Given this list of marker genes Gm11533, Eif5 (NCBI Gene Id 72643), Ubald1, Sf3b4, Il12a, Utp3, 1110002O04Rik, Asap1, H2ac8 (H2A clustered histone 8), Pip5k1a, Cd38, Wdr5b, Esyt2, Neurl1a, Ilvbl, Slc35b4, 1110002E22Rik, Mplkip, Erlec1, Mir8101, Trib2, Entpd6, 4933407L21Rik, Rps15a, Tmem186, Tmem11, Gm6822, Dcaf1, Ndrg4, Sra1, Zbtb18 (NCBI Gene Id 30928), Zfp652, Grk4, Ptprt, Prdm10, Spty2d1, Negr1, Mir7010, Dlgap2, Neurl4, Ccdc163, 1600029O15Rik, Eif2b4, Sumo3, Rasgrp3, Caly, Mrpl30, Kcnj3, Rab15, Nbea, Ndel1, Gas7, Gm15423 (NCBI Gene Id 102640747), Zfp933, Cdca3, Dusp14 (dual specificity phosphatase 14), Ppa2, Rpgrip1l, Lysmd1, Rab40b, Virma, Ccdc61, Nepro, Rufy2, Dbt, Atp6v0a1, Rnu11, Fhad1os2, Rwdd4a, Cad, Cenpu, Dcps, Tars1 (threonyl-tRNA synthetase 1), Rab40c, Dcp1b, Mrpl13, Sox11, Kif1b, Wbp1, Gm25296, Ephb1, Ppp6r1, Wsb2, Usp10, Ninj2, Mindy3, Fhad1, Dbh, Ppt1, Stx1a, Prss36, Atp6v0d1, Zfp146, Ddrgk1, Rad51b, Arap2, Desi1, Kalrn, Ncam1 (NCBI Gene Id 17967), Cdk7, C1ql3, Prrc2a, Akirin2, Cdr1os, Zfp455, Poc1a, Pkd1l3, Gadd45g, Usp2, 4930579G24Rik, Zw10, Gm24552, Nr4a1, Ssc4d, B230369F24Rik, Aggf1, Plpp6, Prrg2, Polr1h, Hspa1l, Arid3a, Hsd11b1, Fer1l4, Map6, Pmm2, Cdk12, Ankrd40, Stxbp1, Ift70a1, Pnrc1, Rtl3, Nhp2, Mmachc, Snx1, Gpn3, Gm38250, Mtcl1 (microtubule crosslinking factor 1), Cbr1b, Rasa3, Ssbp2 (NCBI Gene Id 76496), Carf, Gm25151, Adgrl1, Cstf2t, Zfp524, Zfp719, Rsrc2, Lmo7 (LIM domain only 7), Stambpl1, Crebl2, Zfp260, Gm11465, Garnl3, Tbcd, Gm3764, Hsp90b1, Dip2b, Nop14, Otud6b, Tcap, R3hdm2, Mad2l1, Nolc1, Clvs1, Eif3d, Rpa2, Mir5122, Gramd1b, Yars1, Rhoa, D030040B21Rik, Ckap2l, Commd4, Ankrd28, Ddx41, Ppm1b, Maco1, Btrc, Ciart (circadian associated repressor of transcription), Atxn2l, Ssh2, Cfl1, Mttp, Gm8369, Pgap2, Gabpb2, Tgfbr1, Zfp605, Gm3332, Arhgap11a, Cbx7, Tbc1d23, Celf3, Ipo8, Cpvl, Ephx4, D330050G23Rik, Fbxo5, Fam131a, Fam216a, Tacc3, Gsk3a, Zfp335, Bcas3, Hsf2bp, Smarcb1, Psmb6 (proteasome (prosome, macropain) subunit, beta type 6), Kxd1, Cnep1r1, Gm25939, Pcca, Nuf2, A430005L14Rik, Map3k12, Ugcg (NCBI Gene Id 97164), Elmo2, Mir100hg, Apba2, Tmem184b, Atosa, Or2y1f, Zfp708, Ddx39b, Cox11, Phb2, Setd4, Sirt2, St3gal2, Pkm (pyruvate kinase, muscle), Rubcn, Eif5a, Slc9a1, Pja2, Napg, Gpbp1, Gm29346, Ces1a, Esco1, Arid3b, Mir1945, Anapc7, Gm24641, Rnf126, Rpl18, Haus6, Sugct, Thnsl1, Rab31, Astn1, Hnrnph1 (NCBI Gene Id 59013), Gm15737, Btbd10, Spred2, Kbtbd3, Sptbn2, Trim2, Egr4, Tfg, Gm28578, Arhgap10, 2810408A11Rik, Ubac1, Dhodh, Vipr1, Ppp4r1, Pfkm, Pacsin3, Hycc2, Arl16, Nfkbib, Gm19705 (predicted gene, 19705), Mtbp, Arf2, Serpini1, 9130604C24Rik, Wdr75, Gm15270, Snx16, Phactr3, Il6, Gm8731, Wdpcp, Ache, Azi2, Cyp4x1os, Hmgn1, Fbxo34, 4930445N18Rik, Cnnm1, A430093F15Rik, Ccdc177, Brd2, Upf1 (NCBI Gene Id 382055), Iqgap1, Nav1, Lmod3, Slc17a9, Huwe1, Slit3 (slit guidance ligand 3), Mrpl39, Galk1, Klhl18, Mus81, Fdxr, Pde4d, Zfp715, Gm23104, Smc1a, Med13, H3c6, Sag, Psmd4, Srf, Stag1, Orc1, Esrra, Idua, Tbpl1, Kdsr, Nfya, Mir6343, Rps27, Tiam2, Unc13a, Fap, Flrt3, Mpp2, Ccar1, Gm25602, Etfrf1, Gm23440, Ncoa3 (NCBI Gene Id 99361), Gm25346, Tox4, Gzf1, Birc5, Rasal2, Epha7, Neu2, Il33, A830036E02Rik, Tbc1d14, Gm7430, Ipo11, Mir7228, Rtn1, Rbm25, Htra2, Ddx27, Slc3a2, Gm13383, Gm32496, Atp2a2, Pdss1, Gm13259, Srpk2, Rragd, Nsun5, Tmprss7, Tnc, Rbm6, Zup1 (zinc finger containing ubiquitin peptidase 1), Gm11760, Stxbp4, Zfp35, Etfdh, Mir22hg, Gm8756, Efcab7, Sphk2, Snord43, Osbpl1a, Zcwpw2, Gm14340, Ift81, Pkd2l2, Ppp3r2, Rps26, Myo18a, Gm34139 (predicted gene, 34139), Celf1, Npsr1, Lrif1, Fxr2, Lonp2, Dab2ip, Mzt2, Tpr, Cdpf1, Spata3, Kcnn2, Tex264, Scn2b, Nubp2, Med16, Ppp6c, Vgll4, Rapgef6, Chchd5, Men1, Mycn, Hmbox1, Gm10655, Gm13783, Cops7b, Krtap1-5, Atf7ip, Slc12a8, Ints9, Tmem40, Pex5, Clu, Mettl24, Vmp1, Kat6b, Ppm1h, 2210414B05Rik, Sik2, Nosip, Vldlr, Copa, Rgs3, Pdcd10, Hspa13, Strn4, Emsy, Mad2l1bp, Acin1, Hint3, Mcf2l, Gm13607, Lrrc51, Gm13270, Tyro3, Slc6a21, Map2k6, Ptpa, Ash2l (NCBI Gene Id 23808), Dusp3, Ap2s1, Camk2b, Gtf2i, Ptpn3, Tmed10, Gm23462, Cttnbp2, Tle3, Gm12108, Shank2, Swt1, Ing4, Kntc1, 1110020A21Rik, P4ha1, Iftap, Gm15240, Mtmr9, Rnf44, Psmb3, Fiz1, Or2w3b, Dzip1, Pcm1, Coq10b, Pkig (NCBI Gene Id 18769), Mgat5b, Clk3 (CDC-like kinase 3), Tnr, Lrrc37, Dgkz, Inpp5d, Gm26705, Gm12388, Farsa, Gm5432 (predicted gene 5432), Hgs, Synpo, Smg5, Hkdc1, Adam23, Trp53bp1, Ech1, Ppfia4 (protein tyrosine phosphatase, receptor type, f polypeptide (PTPRF), interacting protein (liprin), alpha 4), Scarna2, Ube2f, Spsb3, Rps27a-ps1, Cstad, Pcdhgc5, Gm16291, Mitd1, Cox20, Gm25855, Tnrc18, Tada3, Znrf1, Hdac5, Tex9, Daglb, Rack1 (NCBI Gene Id 14694), Nudcd3, Asb2, Ccser2, Gng7, Ece2, Tubd1, Cep170, Abr, Fgf9, Rheb, Snd1 (staphylococcal nuclease and tudor domain containing 1), 5830418P13Rik, C2cd5, Dhx29, Epb41l5, Papola, Malat1, Cpa2, Ift20, Get1, Cdrt4os1, Gm25199, Fabp3, Slc6a17, D730003I15Rik, Zc3hc1, Atp6v1d, Leprotl1, Gm24151, Grp, C2cd3, Nrros, Xbp1, 4930568G15Rik, Lin52, Homer1, Ergic1, Gm10570, Plec, D130017N08Rik (NCBI Gene Id 76388), Cyb5d2, Or2y1e, Itgb3bp, Nr1h3, Cic, Fbf1, Psmd1, Ranbp2, 2510017J16Rik, Rapgef2, Rsu1, Ctsa, Usp22, Pisd, Cfap54, Junos, Txnl4b, Gm11665, A830009L08Rik, Specc1, Fli1, Mef2a, Ahctf1, Abcd2, Cept1, Prickle1, 2810459M11Rik, Polr3k, S100pbp, Rusc2, Usp5, Stimate, AI987944, Cep83, Nr3c1, Yipf2, Pth2r, Clip1, Mtmr6, Armc1, Akr1c18, Snora7a, Ext1, Dgat1, Brpf3, Upf3b, Adamtsl2 (NCBI Gene Id 77794), Msh3, Coro1a (coronin, actin binding protein 1A), Rpl32, 4930532M18Rik, Mup5, Csnk1g2, Mir344g, Ints2 (integrator complex subunit 2), Jun, Rexo4, Nme1 (NCBI Gene Id 18102), Ehd3, Gm20752, Abhd11, Atp2b2, Kcnv1, 5033430I15Rik, Cit, Lingo1, H2bc8, Fbxw7, Rab2b, Gm25824, Gm17102, Prkn, Gm22319, Cox5a, Lsg1, Strn3, Sacm1l, Pde7b, Hmgcr, Gm18611, Pttg1ip, A630023P12Rik, Tlcd2, Gm26802 (predicted gene, 26802), Reln, Gm23229, Chordc1, Klf11, Tcta, Dyrk1a, Icam5, Rufy3, Mrps31, Cpne6, Plpp7, Nup205, Csrnp3, Dnai7, Emg1, Stxbp2, Eloc, Pan3 (NCBI Gene Id 72587), Hspa4, Or6b3, Slc35a4, Efcab6, Robo3, Ppme1, Ccdc28b, Rab13 (NCBI Gene Id 77496), Mtf2, Akr1b10, Gm22743, Leo1, Gm14023, Ythdc1, Slc25a19, Mrpl33, Sap30bp, Slc35c2, Eif4g3, Timm29, Arpp19, Wdr12, Gm25894, Gys1, Gm4035, Tmem160 (NCBI Gene Id 69094), Scnm1, Gm6610, Sp4, Slc4a4, Oxr1, 4921504E06Rik, Tnfaip1, Fbxo33, Wdr17, 2810455O05Rik (NCBI Gene Id 72822), Plekha1, Gm28111, Mettl21e, Hmgb4, Arpc4, Rpa3, Tle4, Tfrc, Mgp, Gm42109, Trappc9 (trafficking protein particle complex 9), Tulp4, Car10, Abcc10, Prr14, Calhm5, Inppl1 (NCBI Gene Id 16332), Plcb4, Bsdc1, Tmem125, Pea15a, Snx17, Ppp3cb, Gm6506, Lta4h, Pabpn1, Slc25a11, Elp1, Hipk1, Tcf3, Lrrc8b, Nrdc, Mycbp2, Adck2, 2610035D17Rik, Eif3h, Aknad1, Ribc1, Aasdhppt, Ncoa2, Dusp12, Dclk1, Trmt1l, Gm13983, Rmdn1, Gm12925, Ovol3, 2810025M15Rik, Aldh6a1, Coq8b, Maged1, Rcc2, Enkur, Wdr20, Atxn1, Map3k14, Ap3d1, Ascc2, Ppfia2, Rpl28-ps4, Taco1, Gm807, Tnnt1, Rilpl1, Aarsd1, Pin1, Gm36535, Clpx, Tgm2, Ssbp3, Fndc7, Sox9, Armcx5, Gm23595, Grip2, Grb10, Prkrip1, Slc5a12, Gm16582, Prrt4, Hipk3, Mir8106, Cpd, Prcc, Mink1, Celf2, Dact3, Klf2, 1700028N14Rik, Gtpbp2, Tnpo2, Zfyve26, Hspa1a, Atp13a4, Zfp383, Mgat4c, Map7 (microtubule-associated protein 7), Ndufs7, Fryl, Lca5, Aig1, Pigm, Pars2, Trbv28, Gpt2, 9330104G04Rik, Ift46, Lsm4, Recql5, Map4k4, Nrep, Zfp444, Mdc1, Cd180, Tsen2, Ciao2a, Gpr108, Tomm40, Trappc11, Gm6652, Nme4, Hnrnpl, Aup1, 2700029L08Rik, Rhob, Ppm1l, Sde2, Samd4, Mapk1, Ppp1r12b, Eif2s1, Dtnb, Ncstn, Gm13269, Hk1os, Uba1, Osgepl1, Dgkb, Slc1a2, Map4, 1810062G17Rik, Lemd1, Tldc2, Mff, Limd2, Polr1has, Myo5b, Map9, Cops2, Ttc41, Dusp6, Ttc9b, Mast4, Vps29, Klf9, Zfp106, Thoc1, Zfp46, Sil1, Gm3693, Ndufb3, Myo1b, Gm3294 (predicted gene 3294), Mtrex, Chuk, AI504432, Dnajc16, Trim9, Lin37, Polr3c, Chd2, Phf24, Ywhah, Eif3f, Gspt1, Ric8a, Nptn, Selenoi, Insig2, Ptrh2, 4930447M23Rik, Mapk3, Mrpl24, Acp2, Yipf7, Rbm41, Eml6, Ankrd17, Pacs1, Slco1a5 (solute carrier organic anion transporter family, member 1a5), Zfp62 (NCBI Gene Id 22720), Ak1, Rps18, Oga, H3f3b, Tob1, Dgki, Fbxo16, Gnas, 1500035N22Rik, Asic2, Gm32391, Gm22148, Gm6159, H4c14, Wwox, 1700042D02Rik, Gm11680, Gm5113, Srrm2, Trib1, Pdzd2, Prmt8, Pcbp2, Rap1a, Gprasp1, Neurl2, Galk2, Herc3, Slitrk5, Zswim6, Xrcc6, Klhl38, Rps6kb1, Cd276, Slmap, Ints4, Znfx1, Cadm2, Odr4, Itga6, Ttc7, Nlk, Cacnb4, Ank3, Kif9, Rnf169, Setbp1, Stxbp6, Bet1l, Jph1, Col9a1 (collagen, type IX, alpha 1), Gm26604, Rbm5, Adar, Mon2, Dram2, Anks1b, Psap, Rab10os, Kifc1, Wrnip1, 2310015D24Rik, 2310040G07Rik, Chn1os3, Pkia, Rars2, Myt1l, Acbd5, Vps52, Heg1, Mcrs1, Papss1, BC034090 (cDNA sequence BC034090), Cfap53, Dhx38, Pomp, Cwc25, Hexim2, Dhx34, Rc3h2, N4bp2l2, Cipc, Pacrg, Slc33a1, Gm36211, Mir5110, Snrpc, Tmem79 (transmembrane protein 79), Tarbp2, Usp32, Rpl3, Mir129-2, Klf6, Fnbp4, Gfus, Il11ra1, Zfp1, Creb3, Sys1, Mnt, Avl9, Eef1a2, Snap25, Sirpa, Sptlc2, D930019O06Rik, Ubn2, Cacna2d4 (calcium channel, voltage-dependent, alpha 2/delta subunit 4), Psmc1, Cfap97d1, Nelfa, 1700009C05Rik, Atp1a1, Vps41 (VPS41 HOPS complex subunit), Tmem129, Snap23, Pla2g2c, Zzef1, Adamtsl1, Rskr, Ylpm1, Fto, Lipt1, Hdac9, Paxx, Gpsm1, Dhrs7b, Islr2, Rpl41, D430041D05Rik, Med23, Kif11, Acbd6, Tln1, Med6, B230217C12Rik, Rnf167, Pla2g4e, Psmb7, Mcoln1, Chn1, Abca8b, Hhatl, here is a description of the gene set: from publication Yevshin I, Sharipov R, Kolmykov S, Kondrakhin Y, Kolpakov F (PMID 30445619) Mouse Gene Set: MYEF2_MYEF2L_TARGET_GENES Genes containing one or more binding sites for (Myef2 or Myefl2l) in their promoter regions (TSS -1000,+100 bp) as identified by GTRD version 20.06 ChIP-seq harmonization. species: Mus musculus